Given this list of marker genes SPP1, SDC1, VTN, COL4A5, FGA, CCN1, FN1, ITGB3, COL1A1, PLAUR, EDIL3, SDC4, F11R, COL4A6, SPHK1, COL4A1 (collagen type IV alpha 1 chain), THY1, TGFBI, THBS1, TGFBR2, IBSP, TNC, LAMB1, ITGA2B, LAMC1, HMGB1, LAMA4, PECAM1, COL4A4, PVR, COL4A3, KDR, FBN1, FGB, CD47, PDGFB, COL1A2, L1CAM, PLAU, PDGFRB, FGG, ITGAV, VEGFA, here is a description of the gene set: from publication Schaefer CF, Anthony K, Krupa S, Buchoff J, Day M, Hannay T, Buetow KH (PMID 18832364) Beta3 integrin cell surface interactions studied in species Homo sapiens Human Gene Set: PID_INTEGRIN3_PATHWAY